Given this list of marker genes PCID2, PDIK1L, PAPSS2, CUL9, MYF5, CGREF1, FAM217B, ATP6V0B, POLR1B, USP5 (NCBI Gene Id 8078), RRP12 (ribosomal RNA processing 12 homolog), SH3GL1, VASH2, SRP72, ABCF2, RDH13, MGP, FAM171B, TRIM44, PDIA5, ASS1, CAVIN2, KCTD13, VEGFC, PELO, DDX20 (DEAD-box helicase 20), CREBZF, GPC4, CPNE1, NUP153, PLA2G2E, ATF5, SBF1, CRYBG3, SLC38A7, F8A1 (coagulation factor VIII associated 1), RETSAT, RSPH1, RABL3, ZBTB45, PTCD3, PLEKHA5, IYD, PCGF6, SERPINE1, SSX2IP, HEATR3, OLFML3, TAF3, NEK6, CRIP2, HP1BP3, RPAP3, ZC3H8, TMEM129, DYNC1LI2, UBE2G2, WDR47, WDR6, VPS16, CXCL6, TRIP6, UBE2M, ITGA5, SMC5, DLST, PWP2, GTF2IRD1, SIX1, EXTL2, EIF3L (eukaryotic translation initiation factor 3 subunit L), ZKSCAN8, TTC7B, DCLRE1B, THOC1, MRPS2, DPH2 (NCBI Gene Id 1802), PDCD11, TMF1, MORC2, AK1, PRKG1, DDX27, PHTF1, ABHD8, SLC20A2, EBF3, GAMT, UBLCP1, BBS7, PITPNA, CAVIN3, IGFBP4, TASP1, IL1RN, ARGLU1, CD99L2, CDKAL1, LARS1, ACD, UTP18, NLE1, SLC1A4, SIX4 (NCBI Gene Id 51804, SIX homeobox 4), DIO2, PPRC1, PDIA3, TOE1, LAX1, DDAH1, ATP6V0D1, NOL9, CD80, ACACA, XPO5, ERI3, SLC2A10, MED26, MEIOB, P3H1, CD2BP2, CBLN4, PCOLCE2, NQO1, FKTN, TGFBRAP1, GMPS, DCXR, BTRC, EMC10, MAGI1, GET3, EIF3C (eukaryotic translation initiation factor 3 subunit C), COPA, CECR2, CCNK, ZBTB25 (NCBI Gene Id 7597), EI24, C1orf122 (chromosome 1 open reading frame 122), ZNHIT2, DANCR, ANAPC7, SPRYD3, USP28, AKAP1, PEBP1, UTP4, ELK3, SKI, KTI12, ATL2, TM4SF1, TKT, P2RY2, MAP4K2, UBE2Z, XXYLT1, RUNX1T1, STT3B, ARF1, FADS3, GNPNAT1, MRI1, ATN1, TRAK2, NHLH2, ZNF770, SARS1, SYDE1, NDUFS1, DIS3, RASGEF1A (RasGEF domain family member 1A), ARHGAP35, LRPPRC, SUSD2, B4GALT5, BEND4, LRRN4CL, EXT2, ASXL1, UTP6, URB2, PLPP6, CRKL, FLOT2, TMED2, NFIC, SMN1, RYR1, PUS7L, CAP1, SGMS2, FBXW8, MID1IP1, HNRNPLL, PGM1, EIF2S3, CPT1C, CPNE2, here is a description of the gene set: from publication El Kasmi KC, Holst J, Coffre M, Mielke L, de Pauw A, Lhocine N, Smith AM, Rutschman R, Kaushal D, Shen Y, Suda T, Donnelly RP, Myers MG Jr, Alexander W, Vignali DA, Watowich SS, Ernst M, Hilton DJ, Murray PJ (PMID 17114459) Genes down-regulated in bone marrow-derived macrophages with IL10 knockout and 45 min stimulation by: LPS versus IL6 and LPS. studied in species Homo sapiens Human Gene Set: GSE5589_LPS_VS_LPS_AND_IL6_STIM_IL10_KO_MACROPHAGE_45MIN_DN IL-10 or IL-6 stimulation of control 129xC57BL/6 murine bone marrow derived macrophages in the presence of LPS. We used microarrays to detail the global programme of gene expression changes in response to IL-6 or IL-10 stimulation in the presence of lipopolysaccharide. BMDMs were isolated from control, IL-6-/-, and IL-10-/- mice on a 129XBL/6 mixed background mice and differentiated in the presence of CSF-1 for 6-7 days. Cells were scraped and plated in 6 well plates at 2x10e6/well. Cells were washed with complete DMEM and rested for 1-2 hr before stimulation with combinations of IL-10 (10 ng/ml), IL-6 (2 ng/ml) or LPS (100 ng/ml) for 45 min or 180 mins. Complete biological replicates were performed.